The following is a description of a gene set: Genes down-regulated in naive T lymphocytes lacking FURIN: Cre-Lox knockout of FURIN in CD4+ cells. West Nile virus (WNV), and related flaviviruses such as tick-borne encephalitis, Japanese encephalitis, yellow fever and dengue viruses, constitute a significant global human health problem. However, our understanding of the molecular interaction of such flaviviruses with mammalian host cells is limited. WNV encodes only 10 proteins, implying that it may use many cellular proteins for infection. WNV enters the cytoplasm through pH-dependent endocytosis, undergoes cycles of translation and replication, assembles progeny virions in association with endoplasmic reticulum, and exits along the secretory pathway. RNA interference (RNAi) presents a powerful forward genetics approach to dissect virus-host cell interactions. Here we report the identification of 305 host proteins that affect WNV infection, using a human-genome-wide RNAi screen. Functional clustering of the genes revealed a complex dependence of this virus on host cell physiology, requiring a wide variety of molecules and cellular pathways for successful infection. We further demonstrate a requirement for the ubiquitin ligase CBLL1 in WNV internalization, a post-entry role for the endoplasmic-reticulum-associated degradation pathway in viral infection, and the monocarboxylic acid transporter MCT4 as a viral replication resistance factor. By extending this study to dengue virus, we show that flaviviruses have both overlapping and unique interaction strategies with host cells. This study provides a comprehensive molecular portrait of WNV-human cell interactions that forms a model for understanding single plus-stranded RNA virus infection, and reveals potential antiviral targets. from publication Krishnan MN, Ng A, Sukumaran B, Gilfoy FD, Uchil PD, Sultana H, Brass AL, Adametz R, Tsui M, Qian F, Montgomery RR, Lev S, Mason PW, Koski RA, Elledge SJ, Xavier RJ, Agaisse H, Fikrig E (PMID 18690214) Human Gene Set: KRISHNAN_FURIN_TARGETS_DN species: Mus musculus, and this is the list of marker genes: OPLAH, TSPAN9, SENP8, NCMAP, LEPR, RPF1, ZNF385C, APOL1, KCNIP2 (potassium voltage-gated channel interacting protein 2), PTGR2